The following is a description of a gene set: studied in species Homo sapiens Binding to an anaphase-promoting complex. A ubiquitin ligase complex that degrades mitotic cyclins and anaphase inhibitory protein, thereby triggering sister chromatid separation and exit from mitosis. Human Gene Set: GOMF_ANAPHASE_PROMOTING_COMPLEX_BINDING, and this is the list of marker genes: CLSPN, UBE2S, CCNF, CDC20, CDC20B, PLK1 (NCBI Gene Id 5347), PTEN, FBXO5, FZR1